The following is a description of a gene set: Human Gene Set: GOBP_CENTROSOME_SEPARATION The process in which duplicated centrosome components move away from each other. The centriole pair within each centrosome becomes part of a separate microtubule organizing center that nucleates a radial array of microtubules called an aster. The two asters move to opposite sides of the nucleus to form the two poles of the mitotic spindle. studied in species Homo sapiens, and this is the list of marker genes: CEP85, CNTROB (centrobin, centriole duplication and spindle assembly protein), NDEL1, MAP9, UBXN2B, NSFL1C, KIF11, RANBP1, KIF25, AURKA, NDE1, KIF3B, NUP62, KIF15, CHEK1, NEK2